The following is a description of a gene set: Increases the activity of a protein tyrosine kinase, an enzyme which phosphorylates a tyrosyl phenolic group on a protein. species: Mus musculus Mouse Gene Set: GOMF_PROTEIN_TYROSINE_KINASE_ACTIVATOR_ACTIVITY, and this is the list of marker genes: Egf, Igf2, Alk, Grm5, Ins2, Ercc6, Ltk, Stap1, Epgn, Ins1, Alkal2, Ghrl (NCBI Gene Id 80454), Erbb3, Angpt4, Afap1l2, Btc, Hbegf, Igf1, Grem1, Areg, Nrg1, Cd24a, Htr2a, Egfr, Ngf, Pak2 (NCBI Gene Id 77101), Vegfa, Ccl5, Ereg (NCBI Gene Id 269673), Abi1, Tgfa (NCBI Gene Id 21802), Alkal1, Il6st, Dgkq